Given this list of marker genes NUP155, NUP58, NUP43, NUP160, NUP93, NUP50 (NCBI Gene Id 26132), NUP107, RANBP2, RAN, NUP54, NUP214 (nucleoporin 214), XPO1, NUP98, NUP188, NUP205, HSPA1A, TPR, NUP210, NUP42, POM121C, AAAS, NUP35, POM121, RAE1 (ribonucleic acid export 1), NDC1, NUP62, NUP85, SEC13, NUP153, NUP133, NUP88, NUP37, SEH1L, here is a description of the gene set: Export of Viral Ribonucleoproteins from Nucleus Human Gene Set: REACTOME_EXPORT_OF_VIRAL_RIBONUCLEOPROTEINS_FROM_NUCLEUS studied in species Homo sapiens